The following is a description of a gene set: species: Mus musculus Mouse Gene Set: LIM_MAMMARY_LUMINAL_PROGENITOR_UP INTRODUCTION: Molecular characterization of the normal epithelial cell types that reside in the mammary gland is an important step toward understanding pathways that regulate self-renewal, lineage commitment, and differentiation along the hierarchy. Here we determined the gene expression signatures of four distinct subpopulations isolated from the mouse mammary gland. The epithelial cell signatures were used to interrogate mouse models of mammary tumorigenesis and to compare with their normal human counterpart subsets to identify conserved genes and networks.METHODS: RNA was prepared from freshly sorted mouse mammary cell subpopulations (mammary stem cell (MaSC)-enriched, committed luminal progenitor, mature luminal and stromal cell) and used for gene expression profiling analysis on the Illumina platform. Gene signatures were derived and compared with those previously reported for the analogous normal human mammary cell subpopulations. The mouse and human epithelial subset signatures were then subjected to Ingenuity Pathway Analysis (IPA) to identify conserved pathways.RESULTS: The four mouse mammary cell subpopulations exhibited distinct gene signatures. Comparison of these signatures with the molecular profiles of different mouse models of mammary tumorigenesis revealed that tumors arising in MMTV-Wnt-1 and p53-/- mice were enriched for MaSC-subset genes, whereas the gene profiles of MMTV-Neu and MMTV-PyMT tumors were most concordant with the luminal progenitor cell signature. Comparison of the mouse mammary epithelial cell signatures with their human counterparts revealed substantial conservation of genes, whereas IPA highlighted a number of conserved pathways in the three epithelial subsets.CONCLUSIONS: The conservation of genes and pathways across species further validates the use of the mouse as a model to study mammary gland development and highlights pathways that are likely to govern cell-fate decisions and differentiation. It is noteworthy that many of the conserved genes in the MaSC population have been considered as epithelial-mesenchymal transition (EMT) signature genes. Therefore, the expression of these genes in tumor cells may reflect basal epithelial cell characteristics and not necessarily cells that have undergone an EMT. Comparative analyses of normal mouse epithelial subsets with murine tumor models have implicated distinct cell types in contributing to tumorigenesis in the different models. Genes consistently up-regulated in mammary luminal progenitor cells both in mouse and human species. from publication Lim E, Wu D, Pal B, Bouras T, Asselin-Labat ML, Vaillant F, Yagita H, Lindeman GJ, Smyth GK, Visvader JE (PMID 20346151), and this is the list of marker genes: Ncald, Lpcat1, Rps6kl1, Ggt5, Noxo1, Cd14, Plb1, Elf5, Ccdc88b, Rasgef1c, Csn3, Cxcr4, C1qtnf1, Bbox1, Gne, Wfdc3 (WAP four-disulfide core domain 3), Rftn2, Ckmt1, Cyp24a1, Hivep3, Slc28a3, Slc34a2, Ctsc, Aldh1a3, Asic1, D7Ertd443e, Il15, Foxi1, Tspan33, Itpr2, Slc13a2, Lbp, Pdzk1ip1, Dapp1, Il4i1, Atp6v1b1, Gjb2, Sectm1a, Galnt15, Meltf, Hapln3, Tnfaip2, Csn2, Pigr, Lalba, Qpct, Anpep, Cldn1, C3 (NCBI Gene Id 12266), Xdh, Rasal1, Folr1, Kit, Acsl1, Atp6v1c2, Sorbs2, S100a8, Hsd17b12